Given this list of marker genes SLC6A19, DBR1, NCKAP1L (NCBI Gene Id 3071), CIITA, ERAP1, STXBP2, UNC13D, UBAC2, BCL10, STAT4, KLRC4, IKBKG, PRF1, TLR3, IFNGR1, LBR, FAS, CLTRN, SH2D1A, HLA-B, CCR1, SNORA31 (small nucleolar RNA, H/ACA box 31), C4A, TLR4, IL23R, CD27, TMEM70, TBK1, BTK, IL10, ATRX, CD40LG, IRF4, TRAF3, IL12A, HYOU1, IL12A-AS1, UNC93B1, TICAM1, L2HGDH, XIAP, IRF3, MEFV, STX11, STAT1, here is a description of the gene set: species: Homo sapiens Infectious encephalitis A disorder of the brain caused by an infectious agent that presents with fever, headache, and an altered level of consciousness. There may also be focal or multifocal neurologic deficits, and focal or generalized seizure activity. Human Gene Set: HP_INFECTIOUS_ENCEPHALITIS